Given this list of marker genes RBMXL2, SYCP1, TSSK6, ACRBP, PAPOLB, SHCBP1L, SPO11, DMRT1, SOX30, INSL6, ZPBP, CMTM2 (NCBI Gene Id 146225), SPATA4, POTEB, TULP2, MORC1, ADAM30, CRISP2, GTF2A1L, PIAS2, BRDT, SYCP2, STK31, CABYR, AURKC, SPAG6, RPL10L, SPA17, ZPBP2, here is a description of the gene set: Unmethylated germline-specific genes with high-CpG-density promoters (HCP) in sperm. studied in species Homo sapiens To gain insight into the function of DNA methylation at cis-regulatory regions and its impact on gene expression, we measured methylation, RNA polymerase occupancy and histone modifications at 16,000 promoters in primary human somatic and germline cells. We find CpG-poor promoters hypermethylated in somatic cells, which does not preclude their activity. This methylation is present in male gametes and results in evolutionary loss of CpG dinucleotides, as measured by divergence between humans and primates. In contrast, strong CpG island promoters are mostly unmethylated, even when inactive. Weak CpG island promoters are distinct, as they are preferential targets for de novo methylation in somatic cells. Notably, most germline-specific genes are methylated in somatic cells, suggesting additional functional selection. These results show that promoter sequence and gene function are major predictors of promoter methylation states. Moreover, we observe that inactive unmethylated CpG island promoters show elevated levels of dimethylation of Lys4 of histone H3, suggesting that this chromatin mark may protect DNA from methylation. from publication Weber M, Hellmann I, Stadler MB, Ramos L, Pääbo S, Rebhan M, Schübeler D (PMID 17334365) Human Gene Set: WEBER_METHYLATED_HCP_IN_SPERM_DN